Given this list of marker genes Cdh26, Cdh17, Cdh20, Jup, Cdh7, Ctnna2, Vinac1, Cdh1 (cadherin 1), Cdh11, Cdh15, Cdh19, Cdh2, Cdh6, Cdh8, Cdh4, Dchs1, Cdh5, Cdh18, Apc2, Cdh24 (cadherin-like 24), Cdh9, Cdhr18, Cdh23, Ctnnb1, Ctnnd1, Cdh3, Cdh12, Cdh22, Ctnna1 (NCBI Gene Id 66546), Cdh10, Apc, Cdh13, here is a description of the gene set: Mouse Gene Set: GOCC_CATENIN_COMPLEX Complex of peripheral cytoplasmic proteins (alpha-, beta- and gamma-catenin) that interact with the cytoplasmic region of uvomorulin/E-cadherin to connect it to the actin cytoskeleton. studied in species Mus musculus